The following is a description of a gene set: part of: Cell Cycle, Mitotic This event has been computationally inferred from an event that has been demonstrated in another species.<p>The inference is based on the homology mapping from PANTHER. Briefly, reactions for which all involved PhysicalEntities (in input, output and catalyst) have a mapped orthologue/paralogue (for complexes at least 75% of components must have a mapping) are inferred to the other species. electronically inferred by orthology from the curated human pathway species: Mus musculus Reactome Pathway: Regulation of mitotic cell cycle, and this is the list of marker genes: Psma7, Psma2, Ccnb1, Ube2e1, Ube2d1, Psma3, Psma5, Ube2c, Ccna1, Psmc6, Plk1, Psma1, Cdc23, Aurkb, Psmb5, Cdc14a, Psmd1, Rps27a (NCBI Gene Id 78294), Cdc26, Psmb4, Ube2s, Psmb6, Anapc10, Psmd13, Psmc5, Mad2l1, Psmd12, Anapc15, Psmd7, Psmc2, Psmb7, Cdk1, Psmd6, Psmc3, Psma4, Ubb, Psmc4, Fzr1, Anapc2, Anapc7, Psma6, Rb1, Psmc1, Cul1